Given this list of marker genes SEMA6A, SLC30A4, TCF3, ZFP36L2, SLC6A6, C2orf88, EIF3A, NPTN, CNTN1, CAPN2, CACNB4, PPP3CA, RIMS2, CCL2, LPIN1, DPY19L2, PALLD, CEBPG (NCBI Gene Id 1054), SLC1A4, KATNA1, NEXMIF, PTBP3, JADE1, PIEZO2, RHOG, SNIP1, KLHDC10, C5orf24, TMEM132B, COL8A1, KCTD8 (NCBI Gene Id 386617), PPP4R3B, ETNK1, FOXL2NB, WASF1, ACSL1, CHST1, CCDC50, SEC13, BTC, HAPSTR1, ENPP4, TARBP1, RAB11A, ESRRG, LRRC58, ATP6V0E1, PTPN1, USP14, MMD, CARMIL1 (capping protein regulator and myosin 1 linker 1), NAV2, ZNF559, SEPTIN10, TRIM36, RAB4A, MEIOC, GLT8D1, APBB2, TECTB, TGFBR1, PIK3C2A, TNPO1, CCSAP, ATMIN, OSBPL6, ANTXR2, LRRC8C, SEPTIN11, CCDC90B, AGO4, IGFBP3, PEA15, MAP3K2, ISG20L2, NR5A2, ATF7IP, GZF1, INSM1, PCGF5, SLC50A1 (NCBI Gene Id 55974), AKIRIN1, MAN2A1, HAL, BEND3, KCNQ2, HYCC2 (NCBI Gene Id 285172), RCOR1, ANKRD12, NKAPD1, ITPR3, BEND2, PDCD6, HDAC4, RALGPS1, SELENOI, SAR1B, GALNT13, MRTFB, ZMAT3, NUDT4, MBD2, RAP2A, KCNK9, CYP2U1 (cytochrome P450 family 2 subfamily U member 1), STAC, ITGA11, CERT1, LCP1, SURF4, RPS10-NUDT3, ECRG4, ROCK2, EFNA5, KAT6A, KCNJ6, PLAAT5, RWDD4, ATP6V0A2, SDC2, GON4L, GRIN2A, ETV5, GIT2, PPP2R2A, RRBP1, GXYLT1, MAGT1, LZIC, MORC4, MYRF, GPR37, EPHA3 (EPH receptor A3), ABHD3, TJP1, RAP2B, FERMT2, ARHGAP42, RGS9, MECOM, SLC35B2, ARK2C, SNX4, ACAA2, SERPINB10, CASK, RAVER1, CYTL1, TMEM178A, TMEM263, FLOT2, VSNL1, MAPK14, MGA, DMXL1 (Dmx like 1), ZNF322, C5orf63, VASP, FARP1, HRH4, COL4A1, ANXA7, BRWD3, MYO1C, ELL2, SP1, PIK3CA, MARCHF7, SRPK2, NUDT3, AHR, CDR2L, BTBD10, TET1, P4HA1, RALA, OSBPL3, KIAA0586, KIAA1671 (KIAA1671), G3BP1, ARID4B, CDON, SLC4A7 (NCBI Gene Id 9497), EED, SLITRK6, DIP2B, DMD, PARP16, SNX30, MYZAP, RNPC3, TBC1D9B, DNAJC1, FGFR2, ZNF69, WIPF3, TNFRSF21, SLC16A1, UCK2, PRRX1, PRDM15, ELK4, USP48, MYCL, PIGZ, PTBP1, NR4A3, ZNF706, KCNK10, AMOTL1, TLL1, NFIB, ETV1, CFL2, PRRC2C (proline rich coiled-coil 2C), TEAD1, ULK2, ANXA11, ZNF608, ZNF101, KLHL42, SIGMAR1, MINDY2, SP3, FZD8, EBF3, KCNS3, CCDC6, ADIPOR2, PGRMC2, SUCLG2, BMPR1A, PABIR2, UBA2, RAB6A, TAF13, KCNK2 (potassium two pore domain channel subfamily K member 2), SNX18, JAZF1, GOLM2, MINAR1, TP53INP1, PRKD1, QKI, ANKFY1, BACH2, AXIN2, GNA13, CDK6, CNTN3, PURA, ITPR1, SLC22A16, CUL5, LYSMD3, RASSF8, AGL, RAB27A, PDZD2, CHSY1, SLC39A9, TRA2B, PAXBP1, NCOA2, KLF4, MBOAT2, PUS7 (NCBI Gene Id 54517), SPP2, RICTOR, DDX5, TMED1, PTPN12, AIF1L, NXT2, MRPL49, NR3C2, UBE2B, VAMP3, KLF7, FAM177A1, RBM44, LRRC1, LRP6, MTCL2, FAM91A1, OTUD1, SATB1 (SATB homeobox 1), FAM78A, MYCN, ERMP1, IGDCC4, NR2C2, SLC7A8, RAI14, RECQL, ZDHHC3, EDEM1, ANGPT1, DENND1B, SNCAIP, SLC31A1, FANCF, SLC31A2, CREB3L2, KIAA1549, CYP3A4, ABCA9, KLHL28, PPTC7, ZDHHC6, PLEKHH1, MFSD6, EML6, FAR1, RELA (RELA proto-oncogene, NF-kB subunit), ELP6, OTUD4, EPN2, KLC1, CCDC28A, GGA1, ROR1, CHD1, SMYD3, FRZB, ZNF503, KATNBL1, TMEM168, CCDC68, FNDC3A, PTPN9, BMP6, PDLIM5, CADPS, DCTN4, RTKN2, CBLB, SUGT1, MARCHF8, ESRP1, STT3A (NCBI Gene Id 8071), LRRC7, ARRDC2, TANC2, PDCD5, SERTAD3, MAPRE1, TOMM34, B4GALT1, CYTH3, KCNH7, ELAPOR2 (NCBI Gene Id 222223), MYLK, FKBP15, UACA, MIER3, MYO10, CWC22, RAP2C, MIGA1, SOS1, VCL, ERMN, PLXNB2, RBM20, SLC10A7, MTSS1, ZNF281 (NCBI Gene Id 23528), BEX3, MYLIP, DEPDC5 (NCBI Gene Id 9681), SCN7A, CACNA2D1, PPDPFL, NDFIP1, REEP1, GRIA3, TMEM248, PRTG, RBMS1, NFASC, PRKG1, IREB2, ADSL, CD164, ANXA5, RYR3, SSH2, PAK6-AS1, COL11A1, ARHGDIA, EFCAB14, RXRA, RPIA, GLI3, BBS9, NFATC1, RNF144A, EYA4, NHLRC2, TTL, ELOVL5, here is a description of the gene set: Human Gene Set: MIR3910 Genes predicted to be targets of miRBase v22 microRNA hsa-miR-3910 in miRDB v6.0 with MirTarget v4 prediction scores > 80 (high confidence targets). from publication Chen Y, Wang X (PMID 31504780) studied in species Homo sapiens